The following is a description of a gene set: Pro-B Human Gene Set: HE_LIM_SUN_FETAL_LUNG_C5_PRO_B_CELL species: Homo sapiens from publication He P, Lim K, Sun D, Pett JP, Jeng Q, Polanski K, Dong Z, Bolt L, Richardson L, Mamanova L, Dabrowska M, Wilbrey-Clark A, Madissoon E, Tuong ZK, Dann E, Suo C, Goh I, Yoshida M, Nikolić MZ, Janes SM, He X, Barker RA, Teichmann SA, Marioni JC, Meyer KB, Rawlins EL (PMID 36493756), and this is the list of marker genes: ALDH5A1, H2BC14, TROAP, RFC2, MXD3, DNAJC21, ENG, BIRC5, SOCS2, CENPL, CEP78, N4BP2, ATL3, FGD5-AS1, ANLN, DSN1, FIGNL1, TRIP13, SCCPDH, CHTF18, CCP110, ZNF367, MMS22L, HMMR, H3C8, PRXL2A, H2AC16, GMPS, DEPDC1, MASTL, H4C6, ADGRG1, CDC25C, EXO1, PXMP2, CCDC167, KIF2C, DNTT, TYMS, LIN9, SLC8A1-AS1, NINJ1, SP1, DDX11, CDCA2, H2BC9, FAF1, AAMDC, RRM2, UCK2, UBE2S, AIF1, UHRF1, MCM6, PSMG1, WEE1, DCLRE1B, PKMYT1, MT2A, PLK1, RECK, RDX, H2BC15, CIP2A, LRR1, F13A1, SMS, ZNF771, GNA15, FAM111A, PDZD11, MOV10, H2AC17, SKA3, DNAJC9, PSMC3IP, ARHGAP11A, SRGAP2C, GBP4, CCHCR1, NCAPD2, AURKB, SHMT1, SLC44A1, ZGRF1, MT1X, SGO1, H3C7, TCF7L2, H2BC3, ABHD12, FHL1, DLGAP5, MLLT11, CNTLN, CTNNAL1, TCAF1, C8orf88, H2BC7, RAD1 (NCBI Gene Id 5810), PAQR4, ATG10, GINS3, E2F8, SORBS3, FADS2, PRR11, CBX5, PCNT, MCM10, PLSCR1, CGAS, CENPW, LINC01013, GMNN, TCEAL9, DIAPH3, RCCD1, TCF19 (transcription factor 19), DHRS4L2, FOXM1, CKS1B, KNTC1, RAD54L, CSTF2T, DONSON, KIF14, GAB2, TMEM97, GGH, CRNDE, CDC6 (cell division cycle 6), ARL6IP6, MYBL2, LINC00426, CCNB1, FBXW7, GEN1, POLA1 (DNA polymerase alpha 1, catalytic subunit), TOP2A (NCBI Gene Id 7153), CDC25A, SPDL1 (spindle apparatus coiled-coil protein 1), CDK2AP1, MGAT4A, KIFC1 (kinesin family member C1), CCNB2, S100A1, H4C2, CD34, ARL6IP1, C21orf58, PTTG1, NPY, ANKRD36, MKI67, CDCA3, NAE1, ESCO2, SYNGR1, RAB13, MBOAT2, AP3M2, MCM4 (NCBI Gene Id 780917), TRAIP, CBX2, CENPK, REXO5, BUB1B, LST1 (leukocyte specific transcript 1), EZH2, UBE2T, PARP2, IGF2BP2, PARPBP (PARP1 binding protein), MELK, HJURP, BRD7, RNF168, LCP2, PRC1, YEATS4, CEP41, KIF18A, CLSPN, NCAPH2, DLEU2, PLK4, ERG, ENOSF1, IGFBP7, LMNB2, C19orf48P, LCN6, MIS18A, CKAP2L, SLC27A3, NUF2, CENPH, WDR76, PAFAH1B3, SLC2A5 (NCBI Gene Id 6518), H3C12, CMPK2, SCML2, CDCA7, WDHD1, CDC20, CCNF, TUBGCP3, GPR176, KIF11, TNFRSF1A, STMN3, CENPF, RACGAP1, H3C3, BUB1, SVIP, FANCA, TIMELESS, FANCD2, CRTAP, ITGA5, CDK1, SCMH1, MND1, DNA2, TPX2, MNS1, DSCC1, FAM241A, PHGDH, CIT, RMI2, AMOTL1, VAMP5, FANCL, DTL, NCAPD3, C4orf46, E2F1, GINS1, EBP, ABI2, SERINC5, KIF15, NEIL3, NCAPH, MCM2, H3C14, KIF20B, CCDC88A, FBXO5, VRK1, CENPU, ORC6, CENPO, RNASEH2A, NCF2, CMC2, MCM3, CDK2, KATNAL1, NRIP1, HIRIP3, CHEK1, RFC3, SGO2, BRCA1, PCLAF, H2AC21, CKAP5, HACD3, SMARCD2, ZMIZ1, GINS4, TAF9B, KNSTRN, ALDH7A1, ACYP1, ZWINT, LILRA2, ELK3, PCNA, HLTF, ACAT2, PRIM1, PRKCI, MAP3K20, ARHGEF39, HMGXB4, PRIM2, H2AC8, DHFR, CSE1L, GTSE1, ASPM, TK1, KNL1, CMTM3, GAMT, E2F2, SAC3D1, SEPHS1, NET1, CPT1A, TUBG1, SPATA33, CLEC14A, AURKA, PBK, C5orf34 (NCBI Gene Id 375444), EGFL7, TPGS2, INCENP, ARHGAP33, GPSM2, ADA, CKAP2, CDCA5, CDC45, SPAG5, NCAPG2, H2AC11, CHAF1A, PLEKHA5, FANCG, H3C2, SNCA, DTYMK, UBR7, CENPQ, CCNA2, PALM, SAMD1, PLCB1, HAUS4, CEP152, SMIM3, RBL1, H4C14, CTBP2, CKLF (NCBI Gene Id 51192), HELLS, NDC80, TFDP1 (transcription factor Dp-1), FANCI, BCL2L12, TACC3, H3C15, RMI1, SPC25, CHEK2, HPRT1, POLD1, HYI, TRIM24, UBE2C, CDKN2C, BRCA2, FBLN1 (fibulin 1), POC1A, STK3, RFC4, OIP5, SKA1, RHNO1, AKIP1, RFWD3, CLEC11A, CCDC81 (coiled-coil domain containing 81), KIF23, UNG, KCTD9, H2AC4, CPNE2, TMEM106C, POLD3, ABHD3, CHD3, RBBP8, SLFN13, CEP57L1, TAF5, SMCO4, IFT25, SLC20A1, NENF, H2AC14, DEPDC1B, CCDC34, CCNE2, NUSAP1, E2F7, PGRMC1, KIF22, SYNE2, DDB2, KIF20A, RAD51AP1, NCAPG, SPC24, EPB41L2, RETREG1, H1-5, CHAF1B, CENPN, FADS1, ORC1, GSN, FEN1, PRPSAP1, WWOX, ANXA2R, PHF19, NIPSNAP3A, CDT1, CCN2 (NCBI Gene Id 1490), LIG1, CERS2, FHIT, GINS2 (GINS complex subunit 2), ASF1B, H4C15, GUCY1A1, PSRC1, CENPA, CEP55, BRIP1, CENPE, KMT5A, BARD1, ILVBL, ATAD2, SHCBP1, TTF2, HMGB3, PIDD1, MDK, PIMREG, PXDN, ETS2, CDKN3, MAD2L1, LIMK2 (NCBI Gene Id 3985), FAM111B, TOPBP1, AARS1, CTDSPL2, ATAD5, PDS5B, KIF4A, BEX3, DYNLT2B, CFAP20, SKA2 (NCBI Gene Id 348235), TEDC1, TMPO-AS1, H2AC13, H2BC11, ECT2, SMC2, S100A13, LCORL, RAB34, PKD2, C1QTNF4, H2AC12, TTK, RRM1, NSD2, RASD1, ARMH1, RIF1, CDCA4, CENPM (NCBI Gene Id 79019), SLC43A3, CDCA8